The following is a description of a gene set: Mouse Gene Set: GOBP_POSITIVE_REGULATION_OF_RECEPTOR_BINDING studied in species Mus musculus Any process that activates or increases the frequency, rate or extent of a protein or other molecule binding to a receptor., and this is the list of marker genes: Hfe, B2m, Bdnf, Anxa2, Plcl2, Mmp9, Plcl1